Given this list of marker genes CRMP1 (collapsin response mediator protein 1), DPYSL2, DPYD, TYMP, DPYS, CMPK1, DHODH, DPYSL5, MTOR, CTPS1, CTPS2 (CTP synthase 2), RRM1, DPYSL3, CPS1, CAD, ALDH6A1, CDA, MAPK1, UMPS, DPYSL4, here is a description of the gene set: Human Gene Set: GOBP_PYRIMIDINE_NUCLEOBASE_METABOLIC_PROCESS The chemical reactions and pathways involving pyrimidine nucleobases, 1,3-diazine, organic nitrogenous bases. studied in species Homo sapiens